Given this list of marker genes ACADVL, ACAA2, PPARA, PLIN5, ECHS1, AKT1, ACAT1, AMACR, MTLN, BDH2, ECH1 (enoyl-CoA hydratase 1), HADHA, CRAT, ACADL, MLYCD, PEX7 (NCBI Gene Id 5191), ACOXL, ACOX1, GCDH, HADHB, CPT1B, PEX2, HSD17B10, EHHADH, ACOX3, ABCD3, AKT2, MCAT, TYSND1, DECR1, ECHDC2, LEP, CROT, ACACB, DECR2 (2,4-dienoyl-CoA reductase 2), SESN2, ACADS (NCBI Gene Id 35), ETFBKMT (electron transfer flavoprotein subunit beta lysine methyltransferase), ALDH1L2, HADH, CPT2, ABCD4, ABCD1, TWIST1, HSD17B4, ACAA1, ECI2, AUH, ETFB, ABCB11, IRS1, IVD, ABCD2, IRS2, LONP2, ACOT8, ADIPOQ, ACADM, PPARD, CPT1A, SCP2, PEX5, ACAD11, SLC25A17, ACOX2, MFSD2A, ECI1, ECHDC1, ETFDH, ACAD10, SLC27A2, ETFA, here is a description of the gene set: A fatty acid oxidation process that results in the complete oxidation of a long-chain fatty acid. Fatty acid beta-oxidation begins with the addition of coenzyme A to a fatty acid, and occurs by successive cycles of reactions during each of which the fatty acid is shortened by a two-carbon fragment removed as acetyl coenzyme A; the cycle continues until only two or three carbons remain (as acetyl-CoA or propionyl-CoA respectively). species: Homo sapiens Human Gene Set: GOBP_FATTY_ACID_BETA_OXIDATION